The following is a description of a gene set: species: Mus musculus Mouse Gene Set: GOBP_REGULATION_OF_ESTABLISHMENT_OF_PROTEIN_LOCALIZATION Any process that modulates the frequency, rate or extent of the directed movement of a protein to a specific location., and this is the list of marker genes: Mcu, Plk3 (NCBI Gene Id 12795), Prkar1a, Tgfb2 (NCBI Gene Id 98738), Pde3b, Inhbb, Mup2, Jagn1, Clock, Nutf2-ps1, Cdk1 (cyclin dependent kinase 1), Ptpmt1, Cct6a, Pik3r1, Xpo4, Serp1, Trpm5, Itgam, Tcirg1, Eif3e, Tnfrsf1a, Tfap2b, Egfr, Pfkl, Selenok, Sh3tc2, Ptpn22, Ptbp1, Igf1, Mir130a, Myo1c, Ctsd, P3h1, Midn, Ripor1, Hdac3 (histone deacetylase 3), Pdx1, Ang4, Ptpn1, Sergef, Hsp90aa1, Arhgap44, Ang5, Kcnj6, Rhbdf2, Pcnt, Nsd2, Ergic3, Mup1, Chrm3, Csk, Il6, Eipr1, Tenm1, Tent2, Dctn1, Tgfb1, Epb41l1, Acsl3, Cct8, Chp2, Stxbp4, Cdc42, Pdcd5-ps, Slc9b2, Chrm1, Acd, Ensa, Akap1, Gnas, Nr1h4, Smo, Mtnr1a, Peg12, Cnst, Cacnb3, Idua, Anxa1, Fgb, Hdac6, Hmgcr, Exph5, Trim50, Gpr68, Sytl4, Hsp90ab1, Cd81, Il13, Krt20, Oaz1, Gdi1, Kif5b, Rab11fip1, Kcnb1, Sorl1, Gpr27, Terf1, Rab23, Ptpn11, Nmu, Myom1, Prpf4b, Fgg, Brca1 (NCBI Gene Id 12189), Akt2, Srebf1, Svip, 4930550C14Rik, Umod, Cftr, Slc25a22, Ifi27, Il12b, Ccl5, Fbn1, Tmem30b, Cdk5, Ptp4a3 (protein tyrosine phosphatase 4a3), Pim3, Hmgn3, Ei24, C2cd5, Golph3, Ufm1, Kif20b, Ppid, Tm7sf3, Ankrd1, C1qtnf3, Ppm1f, Gsk3a, Snap91, Abcc8, Cabp1, Arf6, Sybu, Glp1r, Prkd1, Cdk16, Ndel1, Syt4, Neo1, Ano1, Arrb1, Map4k4, Pla2g6, Pak1, Bsg, Rab11a, Cd38, Tpr, Pkia, Nkx6-1, Nlgn2, Mup11, Camk1, Arf1, Gbp4, Fermt1, Gip, Trem2, Trpc1, Cib1, Ice1, Itpr1, Unc13b, Ang, Cct2, Hcfc1, Adipoq, Nucb1, Sfrp1, Capn10, Fto (FTO alpha-ketoglutarate dependent dioxygenase), Uaca, Ywhab, Wipf1, Ppp3ca, Nr0b2, Stom, Ifnb1, Myh10, Trpa1, Bcap31, Gripap1, Ins1, Ect2, Rest, C2cd2l, Slc16a1, Cdk5r1, Sirt3, Crhr2, Lrp5, Cdh1, Prnp, Mup5, Tm9sf4, Chp1, Cct7, Brsk2, Gnao1, Ppm1a, App, Pfkfb2, Vps28, Ipo5, Pdcd10, Camk2n1, Tmem30a, Adcy5, Nr1h3, Nolc1 (nucleolar and coiled-body phosphoprotein 1), Agtr2 (NCBI Gene Id 11609), Ang2, Gprc6a, Kif3a, Foxo1, Abcg1, Lrp2, Stim1, Bmp4, Bnip3l, Apbb1, Nfkbia, Ogt, Gcc2, Mapt, Hras, Gck, Zfand1, Os9, Mief2, Mlxipl, Alox5, Uqcc2, Gja5, Chga, Uts2, A1cf, Crh, Cpt1a, Cln3 (NCBI Gene Id 12752), Erbb2, Hyal2 (hyaluronoglucosaminidase 2), Mpc2, Arpc2, Actr3, Cep120, Bad, Myh9, Cartpt, Fndc1, Foxa2, Cemip, Per2, Lypla1, Cnr1, Tlr2, Oaz3, Rsad2, Xbp1, Ncoa6, Cd36, Mavs, Mtcl1, Nos2 (nitric oxide synthase 2, inducible), Blk, Rab11fip3, Oga, Dmap1, Cela2a, Vamp2, Gli3, Apod, Tcf7l2, Zdhhc2, Ahi1, Xpo1, Piwil4 (NCBI Gene Id 330890), Epb41l5, Ndufaf2, Vsnl1, Trpm2, Siah3, Nf1, Ywhae, Cct5, Apoe, Isl1, Ndfip2, Frat1, Tomm7 (translocase of outer mitochondrial membrane 7), Acvr1c, Idh2, Slc2a2 (NCBI Gene Id 99576), Mff, Erlec1, Hnf4a, Rab29, Mief1, Snx3, Gna11, Ffar1, Lcp1, Dph3, Pik3r2, Ep300, Gper1, Oxct1, Pick1, Cep135, Flna, Mapk14, Sirt7 (sirtuin 7), Zbed6, Drd4, Cacna1d (NCBI Gene Id 97919), Atg7, Tsg101, Prkcz (NCBI Gene Id 97193), Slc1a1, Exoc4, Ubac2, Vamp4, Mir200a, Arhgef5, Arfip1, B3gat3 (NCBI Gene Id 72727), Gas6, Kcnn4, Adtrp, Golph3l, Oaz2, Bglap2, Parl, Rufy3, Gnai1, Sstr5, Gpr39, Anxa7, Efcab7, Rptor, Trim28, Prkce, Mup3, Wwp2, Usp17le, Src, Cyp51, Pparg, Ucp2, Nnat, Psmd9, Grin2a, Fis1, Gnaq, Dkc1 (NCBI Gene Id 56842), Sidt2, Gsk3b, Hpca, Snap25 (synaptosomal-associated protein 25), Rab11fip5, Pcsk1, Ank3, Sec24a, Trpm4, Pde1c, F2, Rhbdd3, Jak2, Itgb1bp1, Wrap53, Tomt, Sirt4, Nol3, Rack1, Prkn, Srcin1, Txn1, Hcar2, Edem2, Malrd1 (NCBI Gene Id 64662), Klf7, Drd2, Yod1, Hnf1a, Ier3ip1, Coro2b, Casr, Ghsr, Sri, Bmal1, Pde4c, Tmem132a (transmembrane protein 132A), Slc7a11, Cct4, Inpp5k, Doc2b, Anxa5, Gnaz, Vamp8, Cd2ap, Lrp1, Tnf, Myrip, Sp100, Glud1, Tiam1, Atp2c1, Cenpj, Efna5, Ptprv, Pfkm, Tmem97, Gipr, Slc12a2, Vegfc, Rfx3, Ptger4, Hcls1, Zc3h12a, Fga, Tunar, Sox4, Il12a, Dnm1l, Mmp13, Cd200, Prkaa1, Baiap3, Pard6a, Psen1, Pmaip1, Ube2g2, Agt, Stx4a, Ucn3, Bbc3, Commd1, Asph, Tbc1d1, Ube2j1, Mdfic, Ang6, Rapgef4 (NCBI Gene Id 71744), Slc8b1, Il1b, Chchd4, G6pc2, Il1a, Vps35, Cask, Cacna1c, Sfn, Pck2, Slc51b, Glul, Or51e2, Nr1d1, Rbp4, Pdcd5, Zfp384, 2700049A03Rik, Sirt1, Egf, Adcy10, Tgfb3, Prkcq, F2rl2 (NCBI Gene Id 268688), Abat, Cep192, Pdzk1, Nos1, Sh3glb1, Zpr1, Dmtn, Cep295, Tcaf1, Myt1, Ffar2, Spidr, Anp32b, Irs2, Ccl2, Zic1, Ppard, Fam3d, Myo18a, Kcnj11, Hm629797, Pkdcc, Insig1, Fyn, Rph3al, Slc30a8, Lrrk2, Ooep, Epha5, Frmd4a, Ptgs2, Angpt1 (NCBI Gene Id 68823), Park7, Prkcd, Wls, Drd3, Cdkn2a, Picalm, Hadh, Nr1h2, Sirt6, Atp13a2, Fbxw7, Camk4, Acsl4, Bag4, Rbm22, Madd, Trh, Frat2, Cplx1, Birc5, Lrrc8a, Rab34 (NCBI Gene Id 19376), Tlr4, Fam76b, Cwh43, Syt7, Jup, F2rl1, Ptpn14, Adora2a, Nutf2, Pde8b, Pcm1, Rap1gds1 (NCBI Gene Id 229877), Adam9, Dnajc1, Gja1, Lepr, Rfx6, Sec16b, Sumo1, Lyplal1, Apbb3, Derl2, Ppp3cb, Cep290, Cep131, Adra2a, Osbp, Abca12 (NCBI Gene Id 74591), Snx12, Cct3, Mdm2, Epm2a, Nup62, Ppia, Syt9, Erp29, Ghrl, Hspa1l, Pink1, Edem1, Cacna1e, Slc35d3, Septin8, Eny2, Ffar3, Tcp1, C1qtnf12, Lep (NCBI Gene Id 16846), Ins2, F2r, Tek, Ctdspl2, Tardbp, Ubr5, Fkbp1b, Scfd1, Aacs, Nadk, Ifng, Tomm70a, Derl3, Nedd1, Emd, Hnrnpm, Rab8a, Kcne1, Nup54, Gm14461, P2rx7, Rhbdf1, Oprm1, Ndfip1, Ccn3, Ttn, Pkig, Ran, Adcy8, Gapvd1, Bard1, Rapgef3, Bag3, Npff, Akap5, Prkcb, Rac1 (NCBI Gene Id 52352), Prkaca, Dnaja1, Dynll1, Mir410, Mtnr1b (melatonin receptor 1B), Orai1, Rangap1, Gcg, Ptpn23, Tmed10, Kcnq1, Hif1a, Mapk1, Pgrmc1, Mup4, Stxbp5l, Plcb1, Tmed10-ps, Prr5l, Nup58, Shh, Irs1, Ptger3, Uhmk1, Gpld1, Ptpn5, Atp5if1